The following is a description of a gene set: studied in species Mus musculus Mouse Gene Set: GOBP_MITOCHONDRIAL_RESPIRATORY_CHAIN_COMPLEX_ASSEMBLY The aggregation, arrangement and bonding together of a set of components to form a mitochondrial respiratory chain complex or between respiratory chain complexes to form high-order structures., and this is the list of marker genes: Oma1 (NCBI Gene Id 67013), Ndufa5, Ndufb6, Chchd4, Sdhaf2, Tmem242, Ndufaf6, Ndufs8 (NADH:ubiquinone oxidoreductase core subunit S8), Ndufaf3, Higd1b, Oxa1l, Smim20, Ndufs4, Tmem70, Ndufb9, Ndufb1, Ndufaf2, Tmem126b, Ndufc1, Uqcrc1, Acad9, Rab5if, Ndufaf7, Bcs1l, Foxred1, Ndufb11b, Timm21, Ndufa13, Cox19, Ndufb4c, Uqcc3 (NCBI Gene Id 107197), Dmac1, Timmdc1, Slc25a33, Higd2a, Uqcc4 (ubiquinol-cytochrome c reductase complex assembly factor 4, NCBI Gene Id 214489), Cox7a1, Atpaf2, Cox7a2, Ndufaf5, mt-Nd5, Ndufa8, Ndufs2, Ndufc2, Ndufb10, Ndufb2, Ndufa10, Higd1c, Cox16, Ndufs7, Lyrm2, Cox17, Sdhaf3, Fastkd3, mt-Nd1, Pet100, Tmem186, Ndufs5, Sdhaf4, Tmem126a, Sdhaf1, Lyrm7, Fmc1, Ttc19, Ndufa11, Coa5, Ndufa3, mt-Nd4, Pet117, Ndufa11b, Nubpl, mt-Nd6, Ndufb11, Cep89, Higd1a, Uqcc2, Atpaf1, Sco2, Ndufb8, Coa3, Ndufb7, Coa6, Uqcc6 (NCBI Gene Id 544717), Chchd7, Sco1, Ndufb5, Samm50, Tfam, Ndufa2, Tafazzin, Ndufs1, Ndufb4, Coa4, Immp2l, mt-Nd2, Stmp1, Ndufb3, Cox18 (cytochrome c oxidase assembly protein 18), Dmac2, Ndufs6, Ndufb4b, Ndufs3, Cox14, Ndufa9, Ndufaf8, Ndufab1, Ndufa6, Ndufab1-ps, Cox20, Atp5f1d, Ndufa1, Taco1 (translational activator of mitochondrially encoded cytochrome c oxidase I), Uqcc1, Uqcc5, Atp23, Cox7a2l, Surf1, Coa8, Ndufaf1, Ndufaf4, Tmem223, Aifm1